The following is a description of a gene set: The circadian timing system coordinates many aspects of mammalian physiology and behavior in synchrony with the external light/dark cycle. These rhythms are driven by endogenous molecular clocks present in most body cells. Many clock outputs are transcriptional regulators, suggesting that clock genes primarily control physiology through indirect pathways. Here, we show that Krüppel-like factor 10 (KLF10) displays a robust circadian expression pattern in wild-type mouse liver but not in clock-deficient Bmal1 knockout mice. Consistently, the Klf10 promoter recruited the BMAL1 core clock protein and was transactivated by the CLOCK-BMAL1 heterodimer through a conserved E-box response element. Profiling the liver transcriptome from Klf10(-/-) mice identified 158 regulated genes with significant enrichment for transcripts involved in lipid and carbohydrate metabolism. Importantly, approximately 56% of these metabolic genes are clock controlled. Male Klf10(-/-) mice displayed postprandial and fasting hyperglycemia, a phenotype accompanied by a significant time-of-day-dependent upregulation of the gluconeogenic gene Pepck and increased hepatic glucose production. Consistently, functional data showed that the proximal Pepck promoter is repressed directly by KLF10. Klf10(-/-) females were normoglycemic but displayed higher plasma triglycerides. Correspondingly, rhythmic gene expression of components of the lipogenic pathway, including Srebp1c, Fas, and Elovl6, was altered in females. Collectively, these data establish KLF10 as a required circadian transcriptional regulator that links the molecular clock to energy metabolism in the liver. from publication Guillaumond F, Gréchez-Cassiau A, Subramaniam M, Brangolo S, Peteri-Brünback B, Staels B, Fiévet C, Spelsberg TC, Delaunay F, Teboul M (PMID 20385766) Human Gene Set: GUILLAUMOND_KLF10_TARGETS_UP species: Mus musculus Genes up-regulated in the liver tissue from 10 week old male mice with KLF10 compared to wild-type littermates., and this is the list of marker genes: SLC25A30, GPR85, IL1F10, WDFY1, FGL1, ALDH18A1, MT1F, RDH12, IL2RB, ITGA4, NNT, SV2A, TFF3, CCR2, SCARA5, RGS5, RSRP1, CCKBR, ADISSP, CD320, TFAP2C, SERPINE2, ATP8A1, NDRG1, DNAJC18, MOXD1, DERL1, COL16A1, KIFC2, CELSR2, DAG1, PCK1, CADM3, CPT1A (NCBI Gene Id 1374), ADAMTS8, SLC22A7, SAA2, SAA1, NNMT, SYT11, STOM, LASP1, ASNS, STEAP1, YWHAZ, MT1X, FEN1, LPL, LCN2 (NCBI Gene Id 3934)